The following is a description of a gene set: species: Homo sapiens The chemical reactions and pathways involving a compound containing a pyrocatechol (1,2-benzenediol) nucleus or substituent. Human Gene Set: GOBP_CATECHOL_CONTAINING_COMPOUND_METABOLIC_PROCESS, and this is the list of marker genes: CHRNB2, VPS35, COMT, MAOB, GATA3, DAO, ITGB2, DRD3, SLC6A3, PARK7, GRIN2A, DRD1, INSM1, SNCB, MOXD1, MOXD2P, DDC, ABAT, DBH, EDNRA, RTL4, KL, HTR1A, PNMT, SULT1A2, PAH, SLC1A1, PDE1B, AOC2, NPR1, GCH1, NT5DC2, SULT1A4, EPAS1, SNCAIP, ITGAM (integrin subunit alpha M), SNCA, SULT1A3, ALDH2, PRKN, SLITRK1, RNF180 (NCBI Gene Id 285671), NPY, DRD2, TACR3, GPR37, ATP7A, PNKD, SULT1A1, GNAT2, HDC, TGFB2, NR4A2, HAND2, TH, HPRT1, MAOA, DRD4